Given this list of marker genes WDR1, SMARCE1, SDR16C5, C1orf116, RBMXL2, CARS1, PPP2R2A, LANCL1, TOX4, TRPC5OS, PIEZO2, ENDOU, SEC31A, ADARB1, EIF1, SLITRK2, ZMYM6, GABRB2, NXT2, DDA1, CACNB2, here is a description of the gene set: Genes predicted to be targets of miRBase v22 microRNA hsa-miR-554 in miRDB v6.0 with MirTarget v4 prediction scores > 80 (high confidence targets). species: Homo sapiens Human Gene Set: MIR554 from publication Chen Y, Wang X (PMID 31504780)